Given this list of marker genes HTR5A, HTR1D, HTR1F, HTR1A, HTR1E, HTR1B, here is a description of the gene set: Combining with serotonin and transmitting the signal across the membrane by activation of the Gi/o subunit of an associated cytoplasmic heterotrimeric G protein complex. The Gi/o subunit subsequently inhibits adenylate cyclase and results in a decrease in cyclic AMP (cAMP) levels. Human Gene Set: GOMF_GI_O_COUPLED_SEROTONIN_RECEPTOR_ACTIVITY species: Homo sapiens